Given this list of marker genes NHLRC1, PPP1R3C (protein phosphatase 1 regulatory subunit 3C), UBB, GYS1, EPM2A, RPS27A, UBC, GYG1, UBA52, here is a description of the gene set: Human Gene Set: REACTOME_MYOCLONIC_EPILEPSY_OF_LAFORA studied in species Homo sapiens Myoclonic epilepsy of Lafora